Given this list of marker genes PBXIP1, SERPINB8, RAP2A, GAS2, PLS1, SELENOP, TRIM16, LAPTM4B, CCL1, TNFRSF4, CFH, COL4A5, CEBPD, BLVRA, DOCK1, ADCY2, FCGRT, TCEAL9, ARHGAP22 (NCBI Gene Id 58504), CRYBG1, SMC4 (structural maintenance of chromosomes 4), PDGFD, SH2D1A, ADGRG1, FAM30A, PIEZO2, SCN9A, NET1, QPRT, ENPP4 (ectonucleotide pyrophosphatase/phosphodiesterase 4), MAP7, IL6ST, IL17RA, AGTPBP1, here is a description of the gene set: studied in species Homo sapiens Human Gene Set: VALK_AML_CLUSTER_3 from publication Valk PJ, Verhaak RG, Beijen MA, Erpelinck CA, Barjesteh van Waalwijk van Doorn-Khosrovani S, Boer JM, Beverloo HB, Moorhouse MJ, van der Spek PJ, Löwenberg B, Delwel R (PMID 15084694) Top genes from cluster 3 of acute myeloid leukemia (AML) expression profile; 84% of the samples are FAB M1 or M2 subtypes, 52% bear intern tandem duplication in FLT3. BACKGROUND: In patients with acute myeloid leukemia (AML) a combination of methods must be used to classify the disease, make therapeutic decisions, and determine the prognosis. However, this combined approach provides correct therapeutic and prognostic information in only 50 percent of cases. METHODS: We determined the gene-expression profiles in samples of peripheral blood or bone marrow from 285 patients with AML using Affymetrix U133A GeneChips containing approximately 13,000 unique genes or expression-signature tags. Data analyses were carried out with Omniviz, significance analysis of microarrays, and prediction analysis of microarrays software. Statistical analyses were performed to determine the prognostic significance of cases of AML with specific molecular signatures. RESULTS: Unsupervised cluster analyses identified 16 groups of patients with AML on the basis of molecular signatures. We identified the genes that defined these clusters and determined the minimal numbers of genes needed to identify prognostically important clusters with a high degree of accuracy. The clustering was driven by the presence of chromosomal lesions (e.g., t(8;21), t(15;17), and inv(16)), particular genetic mutations (CEBPA), and abnormal oncogene expression (EVI1). We identified several novel clusters, some consisting of specimens with normal karyotypes. A unique cluster with a distinctive gene-expression signature included cases of AML with a poor treatment outcome. CONCLUSIONS: Gene-expression profiling allows a comprehensive classification of AML that includes previously identified genetically defined subgroups and a novel cluster with an adverse prognosis.